Given this list of marker genes Npy2r, Rgs13, Htr5a, Tas2r131, Pomc, Nms, Tas1r3, Hrh4, Rho, Rgs9, Ccr10, Chrm4, Ptgdr2, Drd4, Cx3cr1, Lpar3, Casr, Fpr1, Kng2, Ccl21a, Nmu, Tas2r138, Mtnr1a, Oxgr1, Gpr183, Htr1b, Gnai1, C5ar1 (complement component 5a receptor 1), Rgs1, Tas2r130, Cxcr2, Rxfp3, Ppp2r1b, Tas2r144, Tas2r121, Cnr2, Opn1sw, Gnb5, Lpar5 (NCBI Gene Id 381810), Gabbr1, Bdkrb1, Npw, Rgs16, Hcar2, Fpr-rs4, Oprd1, Oprl1, Tas2r119, Drd3, P2ry4, Prkar1b, Ccr4, Cxcl2, Npy1r, Gal, Rgs6, Prkar2b, Rgs14, Pyy, Sstr2, Opn3, Adra2c, C3ar1, Gngt1 (guanine nucleotide binding protein (G protein), gamma transducing activity polypeptide 1), Cdk5, Adcy8, Ccl21e (C-C motif chemokine ligand 21E), Ccr7, Htr1f, Cnr1, Pde1c, Gna14, Gpsm2, Cxcr6, Sstr3, Ccl19, Camkk2, Rgs7, Cxcr4, Gng7, Gpsm3, Gng10, Ccl4, Npb, Gper1, Oprm1, Calm1, Rln3, Galr1, Adcy5, Ccr8, Bdkrb2, Ccl5, Aplnr, S1pr5, Ppp1ca, Opn5, Adra2b, Fpr-rs3, Agtr2, Gnat1, Ccr6 (NCBI Gene Id 12458), Gng11, Prkaca, C3, Tas2r139, Tas2r135, Gng5, Pf4, Cxcl3, Rxfp4, Ccl11, Fpr-rs7, Grm4, Gng3, Sstr4 (NCBI Gene Id 20608), Penk, Gnb2, Rgs8, Gng8, Tas2r120, Gpr17, Ccl9, Prkca, Cxcl1, S1pr4, Ccl20, Hc, Rrh, Nmur1, Ppp2r5d, Adra2a, Cort (NCBI Gene Id 12854), Cxcl10, Tas2r105, Tas2r137, Lpar2, Tas2r136, Sstr1, Tas2r126, Rgs18, Tas2r118, Pde1b, Chrm2, Prkacb, Gnb3, Hebp1, Plcb3, Npy4r, S1pr3, Camkk1, Gnat3, Ccl28, Cxcr5, Ppy, Pnoc, Cxcr3, Rgr, Gng4, Galr3, Sst, Sucnr1 (NCBI Gene Id 84112), Adcy7, Mchr1, Rgs4, Ccl6 (C-C motif chemokine ligand 6), Ccr3, Tas2r107, Psap, Cxcl9, Galr2, Tas1r2 (taste receptor, type 1, member 2), P2ry13, Cxcr1, Tas2r108, Cxcl16, Hcar1, Pcp2, Fpr-rs6, Ccr1, Cxcl12, Insl5, Nmur2, Prkcg, Gngt2, Ccl21f, here is a description of the gene set: This event has been computationally inferred from an event that has been demonstrated in another species.<p>The inference is based on the homology mapping from PANTHER. Briefly, reactions for which all involved PhysicalEntities (in input, output and catalyst) have a mapped orthologue/paralogue (for complexes at least 75% of components must have a mapping) are inferred to the other species. electronically inferred by orthology from the curated human pathway part of: GPCR downstream signalling species: Mus musculus Reactome Pathway: G alpha (i) signalling events